The following is a description of a gene set: Mouse Gene Set: REACTOME_PYRUVATE_METABOLISM studied in species Mus musculus Pyruvate metabolism, and this is the list of marker genes: Pdhx, Glo1, Uba52, Me1, Rmnd5b, Uba52rt, Pdha2, Ubb, Rps27a (ribosomal protein S27A), Pdhb, Pdha1, Dld, Ranbp9, Vdac1, Gid8, Maea (macrophage erythroblast attacher), Ldha, Sirt4, Gpt, Armc8, Ldhal6b, Ldhb, Hagh, Ldhc, Pdk4, Me3, Mkln1, Pdpr, Pdk1, Gstz1, Dlat, Pdp1, Nek1, Wdr26, Ubc, Pcx, Pdk3, Gid4, Rmnd5a (NCBI Gene Id 79046), Me2, Pdk2, Pdp2, Pgam5, Pkm, Fahd1